The following is a description of a gene set: studied in species Mus musculus Proteins secreted in co-culture of LKR-13 tumor cells (non-small cell lung cancer, NSCLC) and MEC stroma cells (endothelium). Human Gene Set: ZHONG_SECRETOME_OF_LUNG_CANCER_AND_ENDOTHELIUM from publication Zhong L, Roybal J, Chaerkady R, Zhang W, Choi K, Alvarez CA, Tran H, Creighton CJ, Yan S, Strieter RM, Pandey A, Kurie JM (PMID 18757440) Non-small cell lung cancer (NSCLC) cells with somatic mutations in K-ras recruit to the tumor a variety of cell types (hereafter collectively termed stromal cells) that can promote or inhibit tumorigenesis by mechanisms that have not been fully elucidated. Here, we postulated that stromal cells in the tumor microenvironment alter the tumor cell secretome, including those proteins required for tumor growth and dissemination, and we developed an in vitro model to test this hypothesis. Coculturing a murine K-ras mutant lung adenocarcinoma cell line (LKR-13) with a murine lung stromal cell (macrophage, endothelial cell, or fibroblast) enhanced stromal cell migration, induced endothelial tube formation, increased LKR-13 cell proliferation, and regulated the secretion of proteins involved in angiogenesis, inflammation, cell proliferation, and epithelial-to-mesenchymal transition. Among these proteins, CXCL1 has been reported to promote NSCLC development, whereas interleukin-18 (IL-18) has an undefined role. Genetic and pharmacologic strategies to inhibit CXCL1 and IL-18 revealed that stromal cell migration, LKR-13 cell proliferation, and LKR-13 cell tumorigenicity required one or both of these proteins. We conclude that stromal cells enhanced LKR-13 cell tumorigenicity partly through their effects on the secretome of LKR-13 cells. Strategies to inhibit tumor/stromal cell interactions may be useful as therapeutic approaches in NSCLC patients., and this is the list of marker genes: ACTC1, ALDH3A1, SERPINC1 (serpin family C member 1), EEF1A2, HMGB1, EEF2, GLO1, VCAM1, LGALS3BP (NCBI Gene Id 3959), CTSZ, TPI1, ACTB, PPIB, BGN, TPT1, RAN, A2M, TKT, LDHA, CLU, AHSG, YWHAG, CTSA, TPM3, VIM, ANXA3 (NCBI Gene Id 306), ALDOA, YWHAE, ENO1, SRSF2, GAPDH, FN1, YWHAZ, CDH1, VCP, CX3CL1, TF, SDC4, CP, TUBA1C, CTSV, CFL2, PCNA, CFB, TUBB, PRDX1, SERPINB6, PHACTR4, PZP, IGFBP7, PEBP1, CLSTN1, KCTD7, CTSD, ALB, C2, TNXB, SPP1, ARHGDIA, COL1A1, GOT1, VCL, IGFBP4, MDH2, RPL10A, ALAD, COL18A1